The following is a description of a gene set: Any process that modulates the rate of GTP hydrolysis by a GTPase. Human Gene Set: GOBP_REGULATION_OF_GTPASE_ACTIVITY species: Homo sapiens, and this is the list of marker genes: GPR137B, FGD5, ARHGAP42, ARHGEF16, FGD2, ARFGEF1, ARHGAP11B, RGS16, ADAP1, ALS2, DOCK8, VAV3, NET1, ITGB1, RACK1, THY1, TBC1D7, FGD6, FGD3 (FYVE, RhoGEF and PH domain containing 3), ADCYAP1, GNB5, RAPGEF1, SH3BP1, RSU1, GPSM1, APC2, RASGRP2, DOCK11, EFNA5 (NCBI Gene Id 1946), SNX9, TBC1D15, RALGAPA2, VAV1, ZC3H15, DOCK9, SGSM3, SOD1, SNX18, RAB3GAP2, SYDE1, ABR, EZH2, EPHA4, S100A10, DAB2IP, RALBP1 (ralA binding protein 1), ARHGAP11A, RCC2, ASAP3, TIAM1, PLXNB1, LIMS1, EVI5L, SCRIB, LRRK2, RASA4, EVI5 (ecotropic viral integration site 5, NCBI Gene Id 7813), RAPGEF2, EPHA2, ITGB1BP1, FICD, RANGAP1, ITGA6, DOCK10, RAB11FIP2, ARAP1, BCR, TBC1D20 (NCBI Gene Id 170488), NGEF, RGS7, CORO1C, PRTN3, ARHGAP44, ECT2, RTN4R, TBC1D2, TSC1, FGD4, LARS1, PLXNB2, RGS6, RGP1, PLXNB3, NF1, RAB3GAP1, RRP1B, KLRK1, USP6NL, TGM2 (NCBI Gene Id 7052), PIP5K1A, ARHGEF5, EPHA5, MMUT, CRK, RIPOR2, NDEL1, RABGAP1, RGS8, EPHA3, PROM2, PRKG1, FGD1, KLRC4-KLRK1, RAP1GAP, BVES, SNX13, NTRK2, RASIP1, RAP1A, VAV2, BCAR3, EPHB3, RIC1, AGRN, ARHGEF7, RHOG, RAPGEF3, RALGAPB, TMED2, MIA2, SRGAP2, F2RL1, DVL3, RGS10 (NCBI Gene Id 6001), RAPGEF6, RALGAPA1, MET, NTRK1, PTK2, SYDE2, MTSS2, ARL2, CCDC125, RGS1, STMN1, SH3BP4, LRCH1, RDX, TBC1D10B (TBC1 domain family member 10B), USP17L2, TBC1D30, SEMA4D, ODAM, SGSM2, SIPA1L1, RASGRP1, RIPOR1